The following is a description of a gene set: studied in species Homo sapiens Human Gene Set: GOBP_NEGATIVE_REGULATION_OF_CELL_ADHESION Any process that stops, prevents, or reduces the frequency, rate or extent of cell adhesion., and this is the list of marker genes: TARM1, PLA2G2D, LILRB1, PDCD1LG2, SPINT2, XCL1, ZNF703, CD9, MIR221, FGL2, APOD, ARHGDIG, TGFBI, CD69, DAB1, ADAM10, IFNA2, CD74, SH2B3, PLXNB2, IL20RB, DEFB118, LPXN, LGALS9C, ADAMDEC1, VSIR, ATP5F1B, ACER2, MMP12, MIR31, RASA1 (NCBI Gene Id 5921), NRARP, PTEN, SFTPD, CSK, MIR146A, ITCH, ANXA1, ANGPT2, PTPRC, BCL6 (NCBI Gene Id 604), PAG1, MAP4K4, FZD4, LAMB1, SLC4A2 (NCBI Gene Id 96677), LRRC32, EFNA5, LGALS9B, ARG2, PLA2G5, PLG, CBLB, MAD2L2, MIRLET7G, ABCA12, RGCC, ARHGAP6, PLXNC1, NOTCH1, SWAP70, AKT1 (AKT serine/threonine kinase 1), ADAM15, LOXL3, PTPN6, KNG1, BMP4, PODXL, MIR92A1, RC3H2, FOXJ1, APOA1, GNRH1, BTN2A2, IL4I1, FZD7, RUNX1, MUC21, HLA-G, PRKAR1A, SOCS1, DLC1, TNFSF4, ANGPT1, CORO2B, NDFIP1, CFL1, PLET1 (NCBI Gene Id 349633), IL10, SEMA3E, MIR939, RDX, HFE, CD86, TNFRSF14, WNT1, IDO1, MAP2K5, DTX1, CBLL1, ZC3H8, TMX1, RUNX3, SOCS6, LILRB2 (leukocyte immunoglobulin like receptor B2), TBCD, ACTN4, CXCL12, MDK, PLXND1, PRNP, VTCN1, ADAMTS18, DSCAM, PLXNB1, TNFSF18, CLEC4G, SERPINE1, TRPV4, TWSG1, CCL21, CBFB, MYOC, ADIPOQ, PELI1 (NCBI Gene Id 57334), MIR675, MAPK7, GTPBP4 (NCBI Gene Id 23560), PTPRO, CR1, SOCS5, PTK2 (protein tyrosine kinase 2), NF1, TBX21, ABL1, MUC1, TNC, SDC4, ERBB3, EPCAM, TIGIT, MIR183, MIR9-1, ASS1, CORO1C, PPARA, SHH, MBP, CDH1, PLXNB3, HMGB1, MARCHF7 (membrane associated ring-CH-type finger 7), PHLDB2, PTPN1, MIRLET7E, LGALS1, PDE3B, DLG5, SNAI2, SEMA4D, SPECC1L, IRF1, FAM107A, CD80, PPM1F, AKNA, CYP1B1, LAX1, ADAM22 (ADAM metallopeptidase domain 22), COL1A1, MIA3, NF2, MIR192, RND1, UBASH3B, HAVCR2, HLX, IFNL1, MIR181C, SPI1, FXYD5, BMP6, TNFAIP8L2, PTPN2, LGALS9, PDCD1, AP1AR, GPNMB, AJAP1 (NCBI Gene Id 55966), MAP2K1, RAG2, MIR30B, TSPAN32, IL4R, MIR10A, CD300A, RHOA, MMP2, MELTF, GLI3, CASK, GCNT2, SPOCK1, HSPG2, ARG1, HRG, JAG1, KLF4, CCL25, LGALS3, MAD1L1, ZC3H12A, STAT5A, DACT2, B4GALNT2, ACVRL1, TACSTD2, LAG3, MIR503, CD164, IFNB1, DMTN, PRKCD, MIR141, JAK3, MIR125A, CX3CL1, LILRB4, ASCL2, SERPINE2, IHH, EPHA4, TNFRSF21, VSIG4, MYADM, CD37, MIR27A, DUSP22, KANK1, IL2RA, CRTAM, NOTCH4, DUSP1, IL1RN (NCBI Gene Id 3557), MIR21, DUSP3, TMEM131L, SCRIB, CLASP2, MIR29C, UFL1, RCC2, PLA2G2F, FBLN1, CEACAM1, CEBPB, PLA2G2A, EPB41L5, SMAD7, CASP3, SPRY4 (NCBI Gene Id 81848), JAK2, VEGFA, PAWR, JAM3, SEMA6A, TNR, WNK1, MIR222, PIK3R1, ERBB2, ADTRP, PRDX2, CDKN2A, EPHB2, IL2, DLG1, ALOX12, RIPOR2, NEXMIF, LAPTM5, BTLA, YTHDF2, PTPN22, PTPN11, METTL3, CDSN, SCGB1A1, SIPA1, GBP1, HLA-DRB1, CDH13, MIR138-1, ZBTB7B, HOXA7, SEMA5A, MMP14, ILDR2, BMP2, C1QTNF1, GLMN, THBS1, ITGB1BP1, FGL1, SPN, CCL28, FOXP3, CTLA4, ADORA2A, POSTN, HLA-E, CD274, TGFB1, SRC, RC3H1, DAPL1, PRKG1, CTSG